The following is a description of a gene set: The removal of an amino group from a nucleotide base in DNA. An example is the deamination of cytosine to produce uracil. studied in species Mus musculus Mouse Gene Set: GOBP_DNA_DEAMINATION, and this is the list of marker genes: Exosc4, Apobec1, Aicda, Exosc6, Cdadc1, Apobec3, Exosc3, Exosc5